Given this list of marker genes F2R, CD247, MRPL23, LMO4, WDR83OS, PATJ, STX18, CXCR3, HSPE1, LCP1, TCF7, KARS1, EEIG1, PGM1, SOCS3, VKORC1, IGBP1, PYCR2, ACP5, SRPK1, TNFAIP8L1, PSMB10, FTL, LUC7L, NOP56, SLC11A2, SLC10A1, PCBP1, TP53, PWP1, MAP2, MEOX2, C2CD3, AFM, BMP7, ZFP36, STIM1, GBE1, RPS5, GSTK1, CMTM7, PPP1R15A, RPL10, PHYH, FOSB, DYM, TUBB, RABAC1, PSMD6, USP3, GRK6, SATB1, ELL, ENTREP3, TP53BP1, GART, XDH (xanthine dehydrogenase), FLT3LG, RFLNB, FBL, GALNT11, ITK, IFNAR2, KLF4, GSTO1, APEX1, CDK4, SRRM2, AQP9 (aquaporin 9), TNIP1, ARL6, TOB1, CNDP2, KCNN4, USP18, HPCAL1, DUSP1, NR2C1, IFRD2, RGS10, SOX5, BANF1, RPSA, CCT6A, PTPRG, SMAD7, MAP3K5, FOXN1, RPS3, ABLIM1, LAMP1, PRDX6, SLC8A1, MOGS, ITGB7, SPRED2, IL4R, EOMES, SSBP2, HSPA1B, HSD17B11, IKBKB, STAM2, DNAJB2, EYA2, COX16 (NCBI Gene Id 51241), MRM3, KLF6, RPL14, RPS6, RAB3D, UBL4A, KLK8, CD7, MKRN1, NRCAM, MYC, MYH11, HYOU1, GLO1, PRSS23, UFD1, PRSS12, LDHA, PIGX, ACTN1, HSP90AB1, GPR65, CRTAM, CSAD, EVL, NFKBIA, HDAC7, PSME1, DNAAF10, TDRP, GZMM, SELL, NUDT3, TMEM126A, HSD17B10, SESN1, LYST, ANXA5, LARP1, LDAH, GATA3, HSD17B8, POLR2H, SCARB2, SOCS1, CCR7, HEXA, LYSMD2, HM13, UBALD2, MCCC1, SMYD2, PSMB9, RRP1B (ribosomal RNA processing 1B), RBM17, GOSR1 (golgi SNAP receptor complex member 1), YES1, DDX21, ITPKB, RNF38, GALNT10, ELOVL5, SBF2, TTC7B, EGR1, SMAD1, AASS, TBCEL, SLC12A7, SHISA5, PPIE, PHPT1, GTF2H4, BCL2, TNF, TSPAN6, SPRYD7, IL7R, PIM2, ABHD14A, UBAP1, GALK1, ATP13A1, JUND, NGDN, FAAH, IL6R, RHBDL3, CD8A, TSPAN31, TTC27, CTNNA1, NSG2, TLR6, here is a description of the gene set: species: Homo sapiens Genes down-regulated in effector CD8 T cells at contraction phase (day 15 after LCMV-Armstrong infection) compared to memory CD8 T cells (day 40+ after LCMV-Armstrong infection). Human Gene Set: KAECH_DAY15_EFF_VS_MEMORY_CD8_TCELL_DN from publication Kaech SM, Hemby S, Kersh E, Ahmed R (PMID 12526810) How and when memory T cells form during an immune response are long-standing questions. To better understand memory CD8 T cell development, a time course of gene expression and functional changes in antigen-specific T cells during viral infection was evaluated. The expression of many genes continued to change after viral clearance in accordance with changes in CD8 T cell functional properties. Even though memory cell precursors were present at the peak of the immune response, these cells did not display hallmark functional traits of memory T cells. However, these cells gradually acquired the memory cell qualities of self-renewal and rapid recall to antigen suggesting the model that antigen-specific CD8 T cells progressively differentiate into memory cells following viral infection.